The following is a description of a gene set: SUMOylation species: Homo sapiens Human Gene Set: REACTOME_SUMOYLATION, and this is the list of marker genes: NR5A2, RORA, NSMCE4A, NR2C1, TFAP2B, SUMO1, H4C4, PIAS1, TOP2B, NFKBIA, ESR1, UHRF2, NR3C2, NSMCE1, HIPK2, BIRC5, PPARG, SMC6, NUP205, NUP85, SUMO3, H4C9, STAG1, BMI1, PARK7, SCMH1, NDC1, PIAS2, RNF2, NR4A2, XPC, MTA1, H4C11, SAFB, NCOA1, SENP1, CDKN2A, H4C13, MITF, TP53, PHC1, NUP210, PHC3, CETN2, NR1H3, NUP42, NSMCE3, HIC1, SIN3A, HDAC2, NOP58, SEC13, IKBKG, ZNF350, EIF2AK2, HNRNPC, NUP107, NUP35 (NCBI Gene Id 129401), NSMCE2, SMC3, ZBED1, MDM2, RELA, SENP2 (SUMO specific peptidase 2), NR1I2, PARP1, POM121C, TFAP2C, EP300, H4C3, SP100, POM121, H4C14, PPARGC1A, CHD3, RANGAP1, H4C15, H4C8, NUP98, PCNA, SUMO2, CBX5, DDX5, NUP155, CTBP1, DDX17, STAG2, VDR, NUP214, XRCC4 (X-ray repair cross complementing 4), TFAP2A, NR1H2, CASP8AP2, MDC1, TPR, H4C12, NCOR2, SAE1, RPA1, L3MBTL2, AURKB, THRB, UBA2, RARA, NPM1, NR5A1, SUZ12, H4C2 (H4 clustered histone 2), RAD52, HDAC7, H4C5, PML, DNMT1, PHC2, NUP58, RING1, RNF168, NFKB2, UBE2I, H4C16, NUP188, IKBKE, MRTFA, WRN, TRIM27, TOP2A, BLM, DNMT3B, TOPORS, NUP153, SP3, CBX2, PCGF2, NCOA2, RWDD3, DNMT3A, AURKA, ING2, TP53BP1, DAXX, NUP43 (nucleoporin 43), SMC5, PIAS3, HERC2, RAE1, HDAC1, EID3, H4C1, SENP5, RAD21, THRA, PGR, SMC1A, AAAS, CBX4, TRIM28, H4C6, NRIP1, CDCA8, FOXL2 (forkhead box L2), NUP62, CBX8, RANBP2, TOP1, NUP37, MBD1, SATB1, HDAC4 (NCBI Gene Id 9759), PIAS4, TDG, NUP93, AR, PPARA, SATB2, SEH1L, INCENP, NUP160, HNRNPK, NR3C1, BRCA1, VHL, CREBBP, NUP133, NUP88, NR1H4 (NCBI Gene Id 9971), NUP54, RXRA, NUP50, ZNF131